Given this list of marker genes TRPC4, NOX4, NCF1, RHOA, MAPK8, STAT3, CASP9, CYBA, CREBBP, CHUK, TGFB1, NPPA, HSPA2, CAMK2A, FSCN1, PRKACA, MAPK14, MAPK9, CDK1, VCAM1, NCF4, AIFM2, SMAD2, COL2A1, UTS2R, MAPK1, AKT1, JAK2, ICAM1, CYBB, CCNE1, PTPN11, NCF2, TNF (tumor necrosis factor), MMP2, NPPB, PTEN, EP300, ESPL1, NFKB1, RELA, HMOX1, CTNNB1, DDIT3, MAPK3, ALOX5, EGFR, PCNA, IKBKB, GSK3B, AGTR1, UTS2, COL1A1, IRF3, COL3A1, BCL2, CDK2, PLN, HDAC5, SMAD3, FN1, ACTA2, MMP9, CASP3, BAX, GSK3A, ABCA1, IL6, IL1B, here is a description of the gene set: Urotensin-II-mediated signaling studied in species Homo sapiens Human Gene Set: WP_UROTENSINIIMEDIATED_SIGNALING